The following is a description of a gene set: Marker genes curated from the annotated cluster as represented in the Descartes Human Gene Expression During Development database. The gene expression program underlying the specification of human cell types is of fundamental interest. The study authors generated human cell atlases of gene expression and chromatin accessibility in fetal tissues. For gene expression, the study authors applied three-level combinatorial indexing to >110 samples representing 15 organs, ultimately profiling ~4 million single cells. The study authors leveraged the literature and other atlases to identify and annotate hundreds of cell types and subtypes, both within and across tissues. Our analyses focused on organ-specific specializations of broadly distributed cell types (such as blood, endothelial, and epithelial), sites of fetal erythropoiesis (which notably included the adrenal gland), and integration with mouse developmental atlases (such as conserved specification of blood cells). These data represent a rich resource for the exploration of in vivo human gene expression in diverse tissues and cell types. Human Gene Set: DESCARTES_FETAL_INTESTINE_VASCULAR_ENDOTHELIAL_CELLS from publication Cao J, O'Day DR, Pliner HA, Kingsley PD, Deng M, Daza RM, Zager MA, Aldinger KA, Blecher-Gonen R, Zhang F, Spielmann M, Palis J, Doherty D, Steemers FJ, Glass IA, Trapnell C, Shendure J (PMID 33184181) species: Homo sapiens, and this is the list of marker genes: EMCN, PCDH12, SOX17, SLCO2A1, TNNT3, APLN, FAM167B, MSX1, SELP, ARHGEF15, DIPK1B, LINC01362, CD34, CLEC14A, NOTCH4, ENSG00000253348, MMRN2, SOX7, PRND, FAM110D, APLNR, MEOX1, CD320, VSIG2, BTNL9, PLVAP, HSPG2, COL15A1, NT5ELP, CYYR1, GPR4 (NCBI Gene Id 2828), SPTBN5, FABP4, FLT1, DLL4, CLEC3B, ESM1, RP1L1, MADCAM1, FABP5, TM4SF18, LHX6, GASK1B, ESAM